The following is a description of a gene set: species: Homo sapiens Genes in discrete regions of gain within 16q region detected in individual invasive breast cancer tumors. Human Gene Set: ROYLANCE_BREAST_CANCER_16Q_COPY_NUMBER_UP We analysed chromosome 16q in 106 breast cancers using tiling-path array-comparative genomic hybridization (aCGH). About 80% of ductal cancers (IDCs) and all lobular cancers (ILCs) lost at least part of 16q. Grade I (GI) IDCs and ILCs often lost the whole chromosome arm. Grade II (GII) and grade III (GIII) IDCs showed less frequent whole-arm loss, but often had complex changes, typically small regions of gain together with larger regions of loss. The boundaries of gains/losses tended to cluster, common sites being 54.5-55.5 Mb and 57.4-58.8 Mb. Overall, the peak frequency of loss (83% cancers) occurred at 61.9-62.9 Mb. We also found several 'minimal' regions of loss/gain. However, no mutations in candidate genes (TRADD, CDH5, CDH8 and CDH11) were detected. Cluster analysis based on copy number changes identified a large group of cancers that had lost most of 16q, and two smaller groups (one with few changes, one with a tendency to show copy number gain). Although all morphological types occurred in each cluster group, IDCs (especially GII/GIII) were relatively overrepresented in the smaller groups. Cluster groups were not independently associated with survival. Use of tiling-path aCGH prompted re-evaluation of the hypothetical pathways of breast carcinogenesis. ILCs have the simplest changes on 16q and probably diverge from the IDC lineage close to the stage of 16q loss. Higher-grade IDCs probably develop from low-grade lesions in most cases, but there remains evidence that some GII/GIII IDCs arise without a GI precursor. from publication Roylance R, Gorman P, Papior T, Wan YL, Ives M, Watson JE, Collins C, Wortham N, Langford C, Fiegler H, Carter N, Gillett C, Sasieni P, Pinder S, Hanby A, Tomlinson I (PMID 16702952), and this is the list of marker genes: CCL17, DOK4, SLC38A7, FTO, AFG3L1P, CIAPIN1, CFAP20, TUBB4A, KIFC3, GAN, DEF8 (differentially expressed in FDCP 8 homolog), PLCG2, MYLK3, GAS8, ADGRG5, MC1R, NLRC5, SHCBP1 (SHC binding and spindle associated 1), PLLP, IRX3 (NCBI Gene Id 79191), CETP, CSNK2A2, RSPRY1, PSMD7, DBNDD1, ANKRD26P1, C16orf78 (chromosome 16 open reading frame 78), CFAP263, CPNE2, ADGRG1, POLR2C, COQ9, CBLN1, MPHOSPH10P1, NDRG4 (NDRG family member 4), ENSG00000187185, ZNF276, RBL2, GINS3, GPT2, DRC7, IL4, PSME3IP1, CNGB1 (cyclic nucleotide gated channel subunit beta 1), KATNB1, OAZ1, GOT2, CX3CL1, CNOT1, SPIRE2, ORC6, RPGRIP1L, TCF25, PRDM7, PRSS54, AKTIP (NCBI Gene Id 64400), CMIP, ADGRG3, VPS35, C16orf87, CDH8, CHD9, CCL22, FANCA